The following is a description of a gene set: This event has been computationally inferred from an event that has been demonstrated in another species.<p>The inference is based on the homology mapping from PANTHER. Briefly, reactions for which all involved PhysicalEntities (in input, output and catalyst) have a mapped orthologue/paralogue (for complexes at least 75% of components must have a mapping) are inferred to the other species. Reactome Pathway: Class I MHC mediated antigen processing & presentation part of: Adaptive Immune System electronically inferred by orthology from the curated human pathway species: Mus musculus, and this is the list of marker genes: Asb10, Rnf7, Psmd1, Fbxo9, Spsb2, H2-M10.1, Hectd2, Asb14, Bcap31, H2-Q7, Mib2, Smurf2, Gan, Arel1, Lnx1, Lrsam1 (NCBI Gene Id 227738), Uba5, Cd36, Asb5 (ankyrin repeat and SOCs box-containing 5), Psma6, Fbxl14, Trim11, Itgb5, H2-M10.6, Fbxl16, Fbxw9, Fbxl21, Fbxo31, Rnf111, Asb12 (NCBI Gene Id 70392), Dtx3l, Ube3c, Ube2g1, Uba1, Psmb10, H2-M3, Rnf6, Psme1, Fbxw4, Psmd13, Fbxo32, Psmd7, Rnf4, Rnf123, Psma1, Cbll1, Pja2, Psma2, Fbxl7, Psmb6, Mrc2, Btbd1, Hecw2, Cblb, Kbtbd8, Herc3, Psmb8, Sec24b, Calr, Erap1, Psme2, Fbxl8, Ube2v1, Psma4, Asb11, Sec24d, Ube2e2, Lrr1, Fbxo10, Cyba, Socs3, Fbxl5, Fzr1, Ubac1, Sec24a, Psmc4, Ube3d, Ubb, Kctd7, Asb16, B2m, Btbd6, Tpp2, Vamp8, Psma7, Anapc10, Tap2, Socs1, Ccnf, Siah1a, Ube2e1, Fbxl3, Trim69, Ube2w, H2-M2, Lonrf1, Rps27a (ribosomal protein S27A), Psmc6, Ube2d1, Ube2r2, Psmb7, Trim32, Ube2s, Fbxl13 (NCBI Gene Id 320118), H2-M10.2, Fbxo27, Arih2, Rnf182, Fbxo17, Ube2k, Smurf1 (SMAD specific E3 ubiquitin protein ligase 1), Ube2o, Psma3, Fbxo40, Trim39, Vhl, Psmb4, Thop1, Cdc26, Kbtbd13, Klhl11, Psmb9, Cul7, Fbxl19, Ube2n, Pja1, Klhl13, Rnf19a, Ube2c, Det1, Glmn, Traip (TRAF-interacting protein), Unkl, Asb8, Trim36, Rnf144b, Cul1, Ncf1, Anapc7, Psmd6, Cdc23, Dcaf1, Rnf126, Hectd3, Ube3b, Ube2e3, Psmc1 (NCBI Gene Id 19179), Tap1, Psmd12, Rchy1, Klhl5 (NCBI Gene Id 71778), Rnf217, Psmc5 (NCBI Gene Id 19184), Lmo7, Kctd6, Anapc2, Fbxl15, Uba7, Rnf213, Trim50, Klhl41, Cdc34, Ufl1, Wsb1, H2-Q10, Asb18, Psmb5, Anapc13, Psma5 (NCBI Gene Id 26442), Cd207, Fbxl4, Ncf2, Psmc3, Trim9, H2-M9 (histocompatibility 2, M region locus 9), Atg7, Sec31a, Fbxo30, Asb9, Prkn, Asb17, Psmc2